Given this list of marker genes DPP4, CXCR2, SLIT2, DEFB104A, BST1, C5AR1, NCKAP1L, PPBP, SLAMF8, CD300A, JAM3, MSMP, PTPRO (NCBI Gene Id 5800), EPX (NCBI Gene Id 8288), PDGFB, GREM1, BSG, NUP85, ADAM8, TIRAP, VEGFD, KITLG, EDNRB, PECAM1, XCL1, SPI1, PTK2B, IL17RA, DEFB124, ANXA1, RTN4, TRPV4, DAPK2, JAML, PTGER4 (prostaglandin E receptor 4), GP2, VAV1, CCL25 (C-C motif chemokine ligand 25), DDT, CD74, CCL16, IL6R, EMP2, CCN3, CCL21, CD177, S100A14, LGMN, THBS1, WDR1, CSF3R, PF4, LBP, TNFRSF11A, S100A12, CX3CR1, ITGA1, MPP1, CD200, CCL28, P2RY12, PERP, CXCL17, LYN, CCL11, TNFAIP6, VAV3, DEFB104B (NCBI Gene Id 503618), CCL22, CXCL3, CCL1, P2RX4, PLA2G1B, IL1B, PRTN3, PDGFD (NCBI Gene Id 80310), CD99L2, S100A9, MCU, JAGN1, MIR24-1, MYD88, IRAK4, CNN2, RPS19, EDN3, C1QBP, CD47, IL34, MAPK1, CXCL9, SWAP70, S100A8, MDK, MIF, CCR1, MIR146A, C5AR2, STAP1, CCR7, PPIB, TGFB2, CD9, CXCL5, CD99, C3AR1, SELENOK, IL1R1, APP, SFTPD, NBL1, PIK3CG, MAPK3, EDN2, TAFA4, CAMK1D, PIP5K1C, MICOS10-NBL1, SLAMF1, MMP28, CALCA, HMGB1, DNM1L, TREM1, ADGRE2 (NCBI Gene Id 30817), SERPINE1, AKIRIN1, CXCL8 (NCBI Gene Id 3576), CCL4, FPR2, SYK, GBF1, SIRPA, CTSG, AZU1, ITGB2, EMILIN1, CYP19A1, THBS4, RABGEF1, CCL5, PAFAH1B1, RAC2, RARRES2, CCL8, PF4V1 (platelet factor 4 variant 1), AGER, UMOD, RIPOR2, PIK3CD, CXCL13, IL23A, IL6, MMP2, DPEP1, BCR, MCOLN2, SCG2, FAM3D, CHGA, NINJ1, VEGFB, TRIM55, CXCL12, ITGA9, PREX1, S100A7 (NCBI Gene Id 6278), VEGFC, CSF1, FCER1G (Fc epsilon receptor Ig), DEFB131A, MIR223, CCL23, CKLF, CCL3, PTPRJ, CCL13, TREM2 (NCBI Gene Id 54209), RPL13A, IL17A, PDE4B, CMKLR1, PIK3R1, CCL4L2, RAC3, PGF, MIR128-1, SRP54, TNFSF11 (NCBI Gene Id 8600), CXADR, CD81, ARHGEF5, IL17RC, CCL26, CCL19, RAC1, STAT5B, ANO6, AIF1, CCL2, B4GALT1, FLT1, MTUS1, CD200R1, CXCL6, DUSP1, FUT7, RIN3 (Ras and Rab interactor 3), LGALS3, MSTN, CREB3, TNFSF18, XG, CCL7, KIT, C5, MMP14, CD300H, NF1, CCL27, EDN1 (NCBI Gene Id 1906), PLCB1, CX3CL1, FUT4, SAA1, PPIA, PLA2G7 (NCBI Gene Id 7941), VEGFA, CCL24, CSF1R, CXCL10, PIKFYVE, PTK2, FOLR2, MOSPD2, CXCR1, CCR2, here is a description of the gene set: species: Homo sapiens Human Gene Set: GOBP_MYELOID_LEUKOCYTE_MIGRATION The movement of a myeloid leukocyte within or between different tissues and organs of the body.